Given this list of marker genes ARHGAP31, NRAS, OFD1, RNASEH2A, RBPJ, PLOD3, SNRPB, RNASEH2B, KRAS, COLGALT1, RNASEH2C, HRAS, EOGT, SAMHD1, COL4A1, ADAR, NOTCH1, CPLANE1, DOCK6, ZNHIT3, NEK1, TREX1, RNU7-1, DLL4 (NCBI Gene Id 54567), GPX4, LSM11, FGFR1, IFIH1, LAMB1, ESAM, TCTN3, COL4A2, here is a description of the gene set: studied in species Homo sapiens Human Gene Set: HP_PORENCEPHALIC_CYST A cavity within the cerebral hemisphere, filled with cerebrospinal fluid, that communicates directly with the ventricular system. Porencephalic cyst